The following is a description of a gene set: Although cancer classification has improved over the past 30 years, there has been no general approach for identifying new cancer classes (class discovery) or for assigning tumors to known classes (class prediction). Here, a generic approach to cancer classification based on gene expression monitoring by DNA microarrays is described and applied to human acute leukemias as a test case. A class discovery procedure automatically discovered the distinction between acute myeloid leukemia (AML) and acute lymphoblastic leukemia (ALL) without previous knowledge of these classes. An automatically derived class predictor was able to determine the class of new leukemia cases. The results demonstrate the feasibility of cancer classification based solely on gene expression monitoring and suggest a general strategy for discovering and predicting cancer classes for other types of cancer, independent of previous biological knowledge. Human Gene Set: GOLUB_ALL_VS_AML_DN studied in species Homo sapiens Down-regulated genes highly correlated with acute lymphoblastic leukemia (ALL) vs acute myeloid leukemia (AML). from publication Golub TR, Slonim DK, Tamayo P, Huard C, Gaasenbeek M, Mesirov JP, Coller H, Loh ML, Downing JR, Caligiuri MA, Bloomfield CD, Lander ES (PMID 10521349), and this is the list of marker genes: AZU1, CST3, LTC4S, CFP, MCL1, CXCL8, CFD, PPIF, CAT, LEPROT, SRGN, HOXA9, ZYX, CTSD, FAH (fumarylacetoacetate hydrolase), ITGAX, LGALS3, LYN (NCBI Gene Id 4067), NFKBIA, LYZ, SQSTM1, STOM, CD33